The following is a description of a gene set: species: Mus musculus The controlled shedding of a body part. Mouse Gene Set: GOBP_ABSCISSION, and this is the list of marker genes: Zfyve19, Chmp4c, Vps4a, Ist1, Spart